Given this list of marker genes Meaf6, Oga, Clock, Abhd14b, Naa40, Naa15, Sat1, Naa30, Ogt, Usp22, Jade1, Kat14 (NCBI Gene Id 99221), Sat2 (NCBI Gene Id 69215), Ep300, Satl1, Gtf3c4, Nat1, Nat14, Naa10, Hgsnat, Naa11, Kat6a, Nat8, Naa12, Jade2 (NCBI Gene Id 76901), Brca2, Kat5, Nat9, Nags, Msx3, Smarce1, Nat8b-ps, Atf2, Kat6b, Cdyl, Nat8f3, Gnpnat1, Atat1, Brd1, Med24, Ncoa3, Taf1, Ncoa1, Kat2b, Hat1, Brpf3, Nap1l2, Gtf2b (general transcription factor IIB), Nat3, Naa80, Mettl8, Crebbp, Ing3, Nat8f7, Naa50, Naa60, Nat8f1, Nat8f4 (N-acetyltransferase 8 (GCN5-related) family member 4), Esco1, Esco2, Aanat, Nat8f6, Tada2a, Kat7, Mcm3ap, Brpf1, Nat8f2, Bloc1s1, Tmem68, Ing4, Taf10, Nat8l (N-acetyltransferase 8-like), Naa20, Kat2a, Phf10, Kat8, Nat2, Pygo2, Nat10, Nat8f5, Taf9, here is a description of the gene set: Mouse Gene Set: GOMF_N_ACETYLTRANSFERASE_ACTIVITY Catalysis of the transfer of an acetyl group to a nitrogen atom on the acceptor molecule. species: Mus musculus